The following is a description of a gene set: Any process that stops, prevents, or reduces the frequency, rate or extent of the directed movement of a motile cell or organism in response to a specific chemical concentration gradient. studied in species Homo sapiens Human Gene Set: GOBP_NEGATIVE_REGULATION_OF_CHEMOTAXIS, and this is the list of marker genes: WNT3, WNT3A, NBL1, PLXNA3, CORO1B, STAP1, C5, THBS1, KLRK1, CXCL13, SEMA5A, PADI2, C5AR2, DUSP3, GSTP1, MMP28, RIN3, CYP19A1, ELANE, MIR223, ROBO2, MIF, SEMA3F, RYK, CCN3, SLAMF8, GREM1, CCL2, KLRC4-KLRK1, WNT5A, DPP4, MICOS10-NBL1, SLIT1 (NCBI Gene Id 6585), DUSP1, PTPN2, DDT, NRP1, AIF1, MIR16-1, HDAC6, MIR149, MIR424, ANGPT2, NOTCH1, SLIT2, GPR18, MIR15A, MIR34A, PTPRO, TNFAIP6, HRG, ROBO1